The following is a description of a gene set: species: Homo sapiens Coronal cleft vertebrae Frontal schisis (cleft or cleavage) of vertebral bodies. Human Gene Set: HP_CORONAL_CLEFT_VERTEBRAE, and this is the list of marker genes: LONP1, ALDH1A2, HSPA9, COL11A2, PEX7, COL2A1, GNPAT, IARS2, HSPG2, SLC26A2, TRIP11 (thyroid hormone receptor interactor 11), LAMA5, TRPV4, CHST3, SLC10A7, ARSL, CSGALNACT1, FLNB